Given this list of marker genes PFDN5, PFDN6, PFDN1, IAPP (NCBI Gene Id 3375), VBP1, LDLR, PFDN2, APOE, TREM2, MIR31 (microRNA 31), CRYAB, PFDN4, HSPG2, CLU, here is a description of the gene set: Any process that stops, prevents or reduces the frequency, rate or extent of amyloid fibril formation. species: Homo sapiens Human Gene Set: GOBP_NEGATIVE_REGULATION_OF_AMYLOID_FIBRIL_FORMATION